Given this list of marker genes TICAM1, IRAK3, TAB2, IRAK1, NFKB1, TBK1, TIRAP, TNF, MYD88, TAB1, RIPK1, IRF7, CXCL8, TRAF6, IFNB1, MAP3K7, NFKBIA, IKBKB, IRF3, IKBKG, INPP5D, TRAF3, TLR4, IKBKE, CHUK, TRAM1, IL6, IRAK4, here is a description of the gene set: TLR4 signaling and tolerance species: Homo sapiens Human Gene Set: WP_TLR4_SIGNALING_AND_TOLERANCE